Given this list of marker genes Utp14b, Retreg1, Prdx3, Vps26a, Rreb1, Dgkh, Smc1b, Tob2, S2bpcox16, Zfhx3, Naa25, Ddx50, Wdr45b, Nt5e, Mylip, Slitrk3, Cox16, Luc7l3, Spred3, Foxf1, Rnf139, Zfp175, Casd1, Metap2, Stag2, Med7, Rab9b, here is a description of the gene set: Mouse Gene Set: MIR_875_5P from publication Chen Y, Wang X (PMID 31504780) Genes predicted to be targets of miRBase v22 microRNA mmu_miR_875_5p in miRDB v6.0 with MirTarget v4 prediction scores > 80 (high confidence targets). species: Mus musculus